Given this list of marker genes CDX2, ABCB1, REG4, CDH17, MUC2, here is a description of the gene set: CDX2-overexpression to transcriptional activation. Pathway ID: N00250. Pathway type: Variant. Pathway class: nt06261 Gastric cancer. Pathway Definition from KEGG: CDX2* => (MUC2,CDH17,REG4,ABCB1) Human Gene Set: KEGG_MEDICUS_VARIANT_CDX2_OVEREXPRESSION_TO_TRANSCRIPTIONAL_ACTIVATION studied in species Homo sapiens